The following is a description of a gene set: A histone octamer slider activity that spaces nucleosomes along chromosomal DNA. This activity is involved in assembling chromatin in uniform nucleosome arrays to regulate transcription by RNA polymerases I, II, and III, as well as DNA replication, recombination and repair. Human Gene Set: GOMF_NUCLEOSOME_ARRAY_SPACER_ACTIVITY species: Homo sapiens, and this is the list of marker genes: SMARCA5, SMARCAD1, SMARCA2, SMARCA4, SMARCA1